The following is a description of a gene set: Up-regulated genes in cervical carcinoma and head and neck tumors positive for human papilloma virus (HPV) compared to those negative for HPV. Human papillomaviruses (HPV) are associated with nearly all cervical cancers, 20% to 30% of head and neck cancers (HNC), and other cancers. Because HNCs also arise in HPV-negative patients, this type of cancer provides unique opportunities to define similarities and differences of HPV-positive versus HPV-negative cancers arising in the same tissue. Here, we describe genome-wide expression profiling of 84 HNCs, cervical cancers, and site-matched normal epithelial samples in which we used laser capture microdissection to enrich samples for tumor-derived versus normal epithelial cells. This analysis revealed that HPV(+) HNCs and cervical cancers differed in their patterns of gene expression yet shared many changes compared with HPV(-) HNCs. Some of these shared changes were predicted, but many others were not. Notably, HPV(+) HNCs and cervical cancers were found to be up-regulated in their expression of a distinct and larger subset of cell cycle genes than that observed in HPV(-) HNC. Moreover, HPV(+) cancers overexpressed testis-specific genes that are normally expressed only in meiotic cells. Many, although not all, of the hallmark differences between HPV(+) HNC and HPV(-) HNC were a direct consequence of HPV and in particular the viral E6 and E7 oncogenes. This included a novel association of HPV oncogenes with testis-specific gene expression. These findings in primary human tumors provide novel biomarkers for early detection of HPV(+) and HPV(-) cancers, and emphasize the potential value of targeting E6 and E7 function, alone or combined with radiation and/or traditional chemotherapy, in the treatment of HPV(+) cancers. Human Gene Set: PYEON_HPV_POSITIVE_TUMORS_UP from publication Pyeon D, Newton MA, Lambert PF, den Boon JA, Sengupta S, Marsit CJ, Woodworth CD, Connor JP, Haugen TH, Smith EM, Kelsey KT, Turek LP, Ahlquist P (PMID 17510386) studied in species Homo sapiens, and this is the list of marker genes: ZBTB18, INTS7, NASP, BTNL9, C18orf54, MPHOSPH9, CEP78, TM7SF3, CENPF, MAP7D2, ZMAT1, ABCA17P, FBXO22, E2F7, PER3, PRELID2, MCM3, KNTC1, JPX, ENSG00000269210, SMARCA2, CASP8AP2, EZH2, GLS2, SANBR, MEIS1, ZNF789, FUBP1, KLHL35, MEI1, NOTCH1, ABCA5, RMI2, DTL, LAMTOR5-AS1, CDC7, CCHCR1, SCAI, TYMS, USP1, SLFN13, LINC00342, CFAP44, CAMTA1, AMY1A, MCM8, TIA1, SLF1, TRIM56, DHFR, BARD1, NEMP1, IL17RB, C5orf34, UHRF1, STAG3, RBBP4, NEURL1B, PNISR, ZSCAN16, WDR76, PDIK1L, CDKN2A, GABPB2, SYCP2, KIF15, TCAM1P, LINC01305, SYNGR3, NR1D2, MYB (NCBI Gene Id 4602), LY75, SLC35E2B, GEN1, GUSBP14, PIK3R3, ZFR2, RTKN2, TAF7L, CENPJ, PRDM15, PSIP1, MIR3939, CDK3, LOC102724701, AHSA2P, CSTF3, SLF2, CDKN2C, TARDBP, ZNF367, CDCA7, ATAD2, HELLS, CENPK, TASOR, LIG1, DONSON, MON2, HENMT1, PLGLB1, EP300-AS1, HNRNPU